The following is a description of a gene set: The switching of activated B cells from IgM biosynthesis to biosynthesis of an IgG isotype, accomplished through a recombination process involving an intrachromosomal deletion between switch regions that reside 5' of the IgM and one of the IgG constant region gene segments in the immunoglobulin heavy chain locus. Human Gene Set: GOBP_ISOTYPE_SWITCHING_TO_IGG_ISOTYPES species: Homo sapiens, and this is the list of marker genes: MLH1 (mutL homolog 1), CD28, FOXP3 (forkhead box P3), PMS2, MSH2, IL4, NDFIP1, IL2 (NCBI Gene Id 3558), IL27RA, ATAD5, TBX21, PAXIP1, PTPRC, CD40, HSPD1, SLC15A4